Given this list of marker genes Gprc5b, Syde1, Arhgap18, Gna12, Pik3ca, Igfbp3, Dad1, Tbc1d2b, Brpf1, Ppard, Nlrp1a, Rictor, Mob3a, Lgals9, Lars1, Arhgap21, Gpihbp1, Ect2, Spdya, Myo9b, Tiam2, Cdc42ep2, Tex24 (NCBI Gene Id 74289), Nupr1, Gdi1, Pdgfb, Bmp4, Rin2, Tbc1d14, Eed, Cdkn1a, Gm2a, Pdgfra, Rabgap1l, Arhgef15, Dock4, Arf1, Mstn, Ranbp2, Ins2, Mnat1, Bmi1, App, Coq8a, Mt3, Als2, Rplp1rt, Rapgef2, Dab2ip, Wnt11, Psmc3ip, Ralgapa2, Tbcd, Agfg2, Ppp4r3a, Map2k1, Rap1gap2, Irgm1 (immunity-related GTPase family M member 1), Atg13, Daxx, Rgs10, Rasa2, Tbc1d16, Arhgap1, Guca1a, Arhgap19, Asap1, Hbegf, Arl2bp, Trem2, Smap1, Tefm, Ophn1, Ptpa, Guca2a, Fam20a, Pdcd5-ps, Prkag2, Tbc1d24, Gapvd1, Dcp1a, Fbln1, Ngf, Arfgap1, Adrm1b, Naa15, Ube2l3, Mid1ip1, Tbc1d1, Cd24a, Raf1, Stap1, Azin1, Egfr, Psme2, Cks1b, Pex12, Prex2, Strada, Ocrl, Gtf2f1, Arhgap9, Clpx, Cdk5r2, Map3k13, Rinl, Apoh, Fgf13, Arf4, Git1, Epgn, Ppp4r3c2, Psme3, Timm50 (NCBI Gene Id 66525), Arap2, Sgsm1, Ube2n, C9orf72, Tsc2, Mapk8ip2, Phactr4 (NCBI Gene Id 97190), Il6st, Cflar, Parp8, Stxbp5l, Tbc1d2, Ppp4r3b, Plaa, Samd15, Cab39, Depdc5, Ccnq (cyclin Q), Aim2, Taok1, Deptor, Tcl1, Rasal3, Tbc1d7, Syngap1, Park7, Rgs18, Psmd14, Vac14, Pcna, Mmp25, Rasal1, Arhgap25, Wnk1, Sh3bp1, Abi1, Igtp, Rgs6, Stxbp5, Mgst2, Wdr20rt, Tcl1b2, Rgs16, Arhgap32, Tbc1d15, Tbc1d30, Naa16, Gdf2, Bcr (NCBI Gene Id 71258), Srgap3, Ankrd27, Agap3, Topbp1, Map3k12, Gmip, Tbc1d21, Tbc1d9b, Ercc5, Arhgap35, Alk, Arhgap20, Ambra1, Dgkq, Parp6, Rgs9, Htr2a, Rgs8, Aph1b, Cav1, Elp2, Rasa4, Slc27a1, Arhgap15, Rgs20, Arhgdib, Dpm3, Acap2, Arhgap22, Srgap1, Slc39a10, Arhgap36, Sgsm3, Cyb5b, Fam13b, Angpt4, Tcl1b3, Dnttip1 (NCBI Gene Id 76233), Agap1, Sav1, Llgl1, Arhgef12, Arhgap5, Areg, Arhgef10l, Mob2, Ccnb1-ps, Llgl2, Gnb5, Ric8a, Adipoq, Nrg1, Plcb1, Erbb3, Tgfa, Naa25, Calm3, Ccnd3, Strit1, Git2, Rgcc, Dpm2, Thy1, Ppp2r5c, Ctsc, Elmod2, Evi5, Arhgap12, Krtcap2, Arhgap31, B3gat3 (beta-1,3-glucuronyltransferase 3), Clpsl2, Rgs11, Tcl1b1 (T cell leukemia/lymphoma 1B, 1), Wdr20, Serinc1, Stard8 (NCBI Gene Id 236920), Fermt2, Rabep2, Lgmn, Coq9 (coenzyme Q9), Tiprl (NCBI Gene Id 67837), Tnfrsf10b, Alox5ap, Cwf19l1, Apoa4, Mob1a, Pak2, Mob1b (MOB kinase activator 1B), Lrrk2, Ranbp1, Tbc1d25, Stk11, Ncs1, Tbc1d8, Rangap1, Ereg, Flcn (NCBI Gene Id 216805), Map2k2, Polg2, Prkcd, Rgs4, Sec23a, Rgs14, Arhgdia (Rho GDP dissociation inhibitor alpha), Apoc2l, Azin2, Ramac, Arhgef1, Noxo1, Rgs7, Sfrp2, Acvr2b, Sipa1l3, Gnas, Rin3, Ralgapa1 (Ral GTPase activating protein, alpha subunit 1), Dock2, Usp6nl, Arhgap42, Cd40lg, Cdc20, Nkx3-1, Gdi2, Jun, Nprl2, Rock2, Mob3b, Stx4a, Iqgap3, Nlrp1b, Plekhg6, Elmod3, Chm, Prss22, Pim1, Arhgap27, Apoe, Arhgap11a, Pik3r1, Rplp1, Ralbp1, Chml (choroideremia-like), Hras, Bmp7, Wrnip1, Rgs5, Ltk, Hmgb1, Igf2, Casp8ap2, Btc, Agfg1, Guca1b, Rab3gap1, Bcas3, Myo9a, Pin1, Bad, Timp2, Rbck1, Clps, Ppp2r5a, Srgap2, Dmwd, Tbc1d13, Tbck, Igf1, Lamtor3, Gm1527, Vrk3, Tbc1d20, Asap2, Bcl10, Rab3gap2 (NCBI Gene Id 98732), Syde2, Nlrc4, Ncstn (NCBI Gene Id 68116), Ssbp1 (single-stranded DNA binding protein 1), Stradb, Nlrp3, Htr2b, Mob3c (MOB kinase activator 3C), Ncf1, Cdk5r1, Itga1, Tgfbr2, Cab39l (NCBI Gene Id 75621), Cbx8, Evi5l, Parp16, Tbc1d22a, Tagap, Aph1c, D1Pas1, Fzr1 (NCBI Gene Id 56371), Grtp1, Rgs12, Arhgap30, Cox17, Rheb, Rap1gap, Sipa1l1, Tbc1d17, Smcr8, Tgfb1, Grm5, Ddost, Arhgap23, Vcp, Afap1l2, Cks1brt, Arl1, Ccl3, Apoc2, Nf1, Dusp19, Nckap1l, Cavin4, Tbc1d9, Arhgap4, Cd33, Arhgap29, P2rx7, Ctsh, Arhgap33, Malt1, Serinc5, Arrb1, Tcl1b5, Depdc1b, Lck, Nanos1, Rp2, Src, Ccnd1, Dock3, Arhgap6, Arfgap2, Prkce, Tbc1d4, Pcolce, Fn1, Noxa1, Irgm2, Acsl1, Iqgap2, Arhgap10 (NCBI Gene Id 78514), Tbc1d8b, Ncf2, Pdpk1, Rps27l, Wfdc21, Mlst8, Rack1, Ajuba, Pin1rt1, Racgap1, Chn2, Ramacl, Psenen, Ppp2r5b, Tbc1d10a, Acap3, Cks2, Gipc1 (NCBI Gene Id 67903), Ccnd2, Sec14l2, Fbxw7, Pdcd5, Rgs1, Prkra, Map3k20 (mitogen-activated protein kinase kinase kinase 20), Dbf4, Arhgap40, Vegfa, Sh3pxd2b, Chn1, Cdkn1b, Epo, Ins1, Casp8, Pde8a, Calm2, Rasgrp3, Arap3, Fam47e, Tbc1d22b, Trmt112, Ghrl, Elmod1, Ltf, Etaa1, Sirt1, Dcp1b, Als2cl, Stard13 (StAR related lipid transfer domain containing 13), Wdr48, Lrcol1 (NCBI Gene Id 381667), Alkal1, Gprc5d, Mtcp1, Tcl1b4, Fnip1, Grem1, Rin1, Entrep1, Apaf1, Ralgapb, Psme4 (NCBI Gene Id 104524), Psme1, Sipa1, Rgs2, Dlc1, Acap1 (NCBI Gene Id 216859), Arhgdig, Rgs17, Calm1, Nrp1, Pycard, Rad50, Ring1, Nsmaf, Spry2, Suz12, Dele1, Ccnt2, Arfgap3, Ccnk, Arhgap17, Sec23b, Iqgap1, Bmp2, Pcgf2, Adap1, Pgam5, Arhgap8, Arhgef19, Ccdc88a, Ppp2r5d, 1700006A11Rik, Egf, Pten (phosphatase and tensin homolog), Sipa1l2, Rabgap1, Rgs3, Dock5, Guca2b, Tbc1d10b, Dnmt3l, Gprc5a, Arap1, Fyn, Adgrb3, Depdc1a, Svbp, Acrbp, Pcolce2, Dazap2, Gpr158, Ltc4s, Nanos2, Wdr4 (WD repeat domain 4), Garnl3, Nanos3, Sdhaf4, Ercc6, Ppp4r3c1, Ccnt1, Apoa1, Tbc1d5, Btk, Abr, Tbc1d10c, Abhd5, Tank, Tom1l1, Sgsm2, Rasa1, Ppp2r5e, Hspd1 (NCBI Gene Id 15510), Arhgap44, Nek9, Btrc, Mapk9, Eef1a1, Ccnb1 (cyclin B1), Gprc5c, Mtss2, Sh3pxd2a, Rptor, Alkal2, Vsir, Tab1, Tifab, Arhgap39 (Rho GTPase activating protein 39), Rasa3, Ccl5, Ddx3x, Casp3, Smap2, Eif5, Tbc1d12, Gnaq, Adap2, Arhgap24, Insr, Arhgap26, Cdc20b, Prex1, Ccl8, Slx4, Nbn, Aph1a, Agap2, Gcn1, Apoa2, Pdzd11, Arhgap45, Adrm1, Hsp90ab1, Ncf4, Prr5 (NCBI Gene Id 97963), Arhgap28, Apobec1, Asap3, Atp2a3, Nprl3, Rabep1, Itsn1, Apoa5, here is a description of the gene set: studied in species Mus musculus Binds to and increases the activity of an enzyme. Mouse Gene Set: GOMF_ENZYME_ACTIVATOR_ACTIVITY